Given this list of marker genes NPR2, FGFR1, LMBR1, HOXD13, TRPV4, LZTFL1, RBPJ, CHSY1, HDAC4, ZNF407, SRY, PRKG2, PORCN, RAB33B, FAT4, VPS13B, PIK3CD, KNSTRN, SALL1, PRKAR1A, TRPS1, BMPR1B, EP300, WNT7A, FGFR2, EZH2, GDF5, PHYH, PEX7, TP63, RSPRY1, SMARCA2, POC1A, PDE4D, VPS35L, IQCE, DCHS1, TWIST1, HINT1, IFT140, COG4, B3GLCT, HOXA13, EBF3, FLNB, HEPHL1, PIGS, CANT1, FIG4, FBN1, ITPR1, IFT52 (NCBI Gene Id 51098), TCF4, SIL1, SLC26A2, ERI1, KCNJ2, GNAS, PRMT7, CDC42BPB, MAP3K7, FLNA, COL2A1, DYM, RIPK4, PTHLH, here is a description of the gene set: Aplasia/Hypoplasia of metatarsal bones Absence or underdevelopment of the metatarsal bones. species: Homo sapiens Human Gene Set: HP_APLASIA_HYPOPLASIA_OF_METATARSAL_BONES